Given this list of marker genes CACNA1G, HCN1, TNNI3K, HCN3, GJA5, PKP2, TRPM4, CAV1, SCN10A, ATP1A1, KCNN2, GJA1, ATP1B1, ATP1A2, MIR328, GJC3, CALM2, KCNE5, MIR208A, GJD3, CACNA1D (NCBI Gene Id 776), RYR2, PRKACA, DSC2, NUP155, TRDN, SCN3B, SLC8A1, CACNA2D1, ATP1B2, TBX5, ANK2, CTNNA3, KCNJ5, ATP1A3, SRI, KCNQ1, DSP, RANGRF, CACNB2, DSG2, CALM1, SCN5A, KCNJ3, CACNA1C, CALM3, FLNA, SCN4B, CXADR, CASQ2, SCN1B, HCN4, JUP, CAMK2D, TBX18, PDE4D (NCBI Gene Id 654081, phosphodiesterase 4D), KCNA5 (potassium voltage-gated channel subfamily A member 5), IRX3, HRC, GJC1, here is a description of the gene set: Any process that mediates interactions between a cell and its surroundings that contributes to the process of cardiac conduction. Encompasses interactions such as signaling or attachment between one cell and another cell, between a cell and an extracellular matrix, or between a cell and any other aspect of its environment. Human Gene Set: GOBP_CELL_COMMUNICATION_INVOLVED_IN_CARDIAC_CONDUCTION species: Homo sapiens